The following is a description of a gene set: Reactome Pathway: Cargo concentration in the ER part of: ER to Golgi Anterograde Transport studied in species Mus musculus electronically inferred by orthology from the curated human pathway This event has been computationally inferred from an event that has been demonstrated in another species.<p>The inference is based on the homology mapping from PANTHER. Briefly, reactions for which all involved PhysicalEntities (in input, output and catalyst) have a mapped orthologue/paralogue (for complexes at least 75% of components must have a mapping) are inferred to the other species., and this is the list of marker genes: Cnih3, Cnih2, Areg, Ctsc, Col7a1, F8, Lman1, Sec24b, Lman2l, Folr1, Lman1l, Tmed10, Sec24a, Sec24d, Tgfa